Given this list of marker genes Gbp7, Gbp4, Tgtp1, Irgm1, Igtp, Samhd1 (SAM domain and HD domain, 1), Edem1, Psmb9, Serpina3f, Ppa1, Mdp1, Irgm2, Psme2, Psmb10, H2-T23, Gbp8, Gbp2, Ifi47, Stat1, Xaf1, Iigp1, Mpp1, Serpina3g, Tap2, Phyh, here is a description of the gene set: from publication Cui A, Huang T, Li S, Ma A, Pérez JL, Sander C, Keskin DB, Wu CJ, Fraenkel E, Hacohen N (PMID 38057668) Cytokines mediate cell-cell communication in the immune system and represent important therapeutic targets. A myriad of studies have highlighted their central role in immune function, yet we lack a global view of the cellular responses of each immune cell type to each cytokine. To address this gap, the authors created the Immune Dictionary, a compendium of single-cell transcriptomic profiles of more than 17 immune cell types in response to each of 86 cytokines (>1,400 cytokine-cell type combinations) in mouse lymph nodes in vivo. A cytokine-centric view of the dictionary revealed that most cytokines induce highly cell-type-specific responses. For example, the inflammatory cytokine interleukin-1β induces distinct gene programmes in almost every cell type. A cell-type-centric view of the dictionary identified more than 66 cytokine-driven cellular polarization states across immune cell types, including previously uncharacterized states such as an interleukin-18-induced polyfunctional natural killer cell state. studied in species Mus musculus Mouse Gene Set: CUI_ILC_IFNG_RESPONSE_UP Genes positively differentially expressed in cell type: ILC (innate lymphoid cell) upon treatment with cytokine: IFN-γ in mouse lymph nodes in vivo.